The following is a description of a gene set: studied in species Homo sapiens Reactome Pathway: Metabolism of proteins Metabolism of proteins, as annotated here, covers the full life cycle of a protein from its synthesis to its posttranslational modification and degradation, at various levels of specificity. Protein synthesis is accomplished through the process of Translation of an mRNA sequence into a polypeptide chain. Protein folding is achieved through the function of molecular chaperones which recognize and associate with proteins in their non-native state and facilitate their folding by stabilizing the conformation of productive folding intermediates. Following translation, many newly formed proteins undergo Post-translational protein modification, essentially irreversible covalent modifications critical for their mature locations and functions, including gamma carboxylation, synthesis of GPI-anchored proteins, asparagine N-linked glycosylation, O-glycosylation, SUMOylation, ubiquitination, deubiquitination, RAB geranylgeranylation, methylation, carboxyterminal post-translational modifications, neddylation, and phosphorylation. Peptide hormones are synthesized as parts of larger precursor proteins whose cleavage in the secretory system (endoplasmic reticulum, Golgi apparatus, secretory granules) is annotated in Peptide hormone metabolism. After secretion, peptide hormones are modified and degraded by extracellular proteases (Chertow, 1981 ). Protein repair enables the reversal of damage to some amino acid side chains caused by reactive oxygen species. Pulmonary surfactants are lipids and proteins that are secreted by the alveolar cells of the lung that decrease surface tension at the air/liquid interface within the alveoli to maintain the stability of pulmonary tissue. Nuclear regulation, transport, metabolism, reutilization, and degradation of surfactant are described in the Surfactant metabolism pathway. Amyloid fiber formation, the accumulation of mostly extracellular deposits of fibrillar proteins, is associated with tissue damage observed in numerous diseases including late phase heart failure (cardiomyopathy) and neurodegenerative diseases such as Alzheimer's, Parkinson's, and Huntington's., and this is the list of marker genes: MUC13, APCS, COPS8, SPTBN2, SEC61G (SEC61 translocon subunit gamma), FBXO17, MRPL39, GLB1, ALAS1, UBB, TTLL10, FURIN, AGTPBP1, FBXO2, USP17L4, MARS2, RAB8A, CD55, TRAPPC1, DPP4, RPS11, ARF5, CLPP (caseinolytic mitochondrial matrix peptidase proteolytic subunit), TPR, LY6K, SLC25A6, STC2, RAB14, RAB40A, MVD, RPS16, 5S rRNA, ALG13, MRPL38, PSMA7, LMAN1L, RPL13, RBBP5, MRPS33, NAPG, FOLR1, GADD45GIP1, STARD7, PFDN6, ALG11, KBTBD8, RPL36AL, CKAP4, SBSPON, LAMB1, HDAC2, AMELX, KEAP1, PSMA5, SEC24A, SSPOP, EIF2B5, UBE2L3, RAB3A, BTBD1, WAC, SSR1, MUC4, ARFGAP1, NDUFV3, HSPD1, F2, GNG10, UBE2C, PSMD4, NFU1, TMED2, TOP2A, XRN2, DCAF16, FBXL14 (NCBI Gene Id 144699), RGS9, ST6GALNAC3, LY6G6C, PARK7, CST3, KBTBD6, PSMD2, ARSG, B4GALT3, PNPLA2, TARS2, MT-ATP8, ASB8, MRPL41, PIGO, PSME3, USP17L13, AMBN, SMAD1, SMDT1, UBC, USP10, DDX17, CHST4, MTIF2, RAB38, IGFBP5, SRP68, AAAS, ASB17, MGAT4B, TIMM17A, MT-TE, VAMP2, TFAM, STAM, USP17L19, COMMD8, VNN1, MYRIP, LYPD4, TSPAN33, RPS23, SQSTM1, KLHL21 (kelch like family member 21), GATA6, STT3A, UBA3, SOCS6, PARS2, TCP1, PSMF1, HIPK2 (homeodomain interacting protein kinase 2), MT-TV, FSTL3, EIF2B4, ADAMTS3, RGS7, SP3, FBXO22, CLPX, STAM2, MRPL27, CMA1 (chymase 1), EIF3B, USP7, SARS2, ATP5F1B, RPS27A, USP15, SLC34A1, MT-ND3, BMP15, PEX14, TF (NCBI Gene Id 7018), UBE2Z (NCBI Gene Id 65264), TDG, GCG, ST8SIA4, RPS6, MT-TI, FBXO11, CALB1, IDE, CNTN3, GZMH, PPA1, ETFBKMT, PSMD1, RNF181, CTSA, VARS1, RPL13A, GALNT14, UQCRC2, TUBA8, CCT6A, PROS1, H2AC14, UBE2M, FBXO44, NDUFA2, PSMD6, RNF135, MARS1, RBX1, NUP107, LARS1, DYNLL1, COG4, DYNC1LI1, RNF40, TGFB1, DLAT, DCAF13, MRPL28, CES1, AURKB, ADAMTS20, IL6, KLHL2, CALM1, CUL1, KLHL41, ADAMTS16, CCT4, KLHL42, RPLP0, GH1, RRAGA, TRIM4, RPS28, WRN, EARS2, NR5A2, SUDS3, PMM2, NUP133, GGCX, SAA1, AMFR, SENP8, MRPL3, LARGE2, STS, MDC1 (NCBI Gene Id 9656), COPS7B, RPL9, JOSD1, MT-TL2 (mitochondrially encoded tRNA-Leu (CUN) 2), GNAQ, CPM, RNF144A, RAB3D, TUBB2A, SSR3, TMED7, SPTAN1, KGD4, RAET1L (retinoic acid early transcript 1L), ASB2, HCFC1, ASGR1, LTN1, RPS27 (NCBI Gene Id 6232), GALNT2, EXOC5, SEC24C, NFRKB, CUL2, STAMBP, COG8, DCUN1D2, THBS1, SLC25A5, PGAP1, RPS25, FFAR4, TGFBR2, WDR20, TFAP2B, KLK2, MRPS21, CD109, EEF1D, TUBB1, DCAF8, UMOD, APH1B, IZUMO1R, PAPPA, TBCA, ST3GAL6, TOMM70, NARS2, DNAJC24, NCSTN, TARS1, ADAMTS10, SUZ12, PSMD3, OTULIN, F5, MTA1, RNF146, PIGC, TUBA3C, PSMA2, SLC35A4, FBXL8, AGBL1 (NCBI Gene Id 728206), CARS1, AFG3L2, CCNA1, TTLL8, RPL27A, CSNK2A1, MRPS35, RAB39B, MRPL33, SRP19, PRKN, PAPPA2, ZNF598, ACHE, MT-TK, MTIF3, TPGS1, AR, MRRF, GALNTL6, H2AC21, CALCA, NDUFA13, RABGGTB, GOSR2, NUP188, 7SL RNA (ENSG00000222639), PCSK9, STT3B, COG5, ADAMTSL4, EXOC2, SPP2 (NCBI Gene Id 6694), EIF4A2, ABCA3, MT-ND1, EID3, FBXL18, CHRDL1, CSNK2A2, VASH2, RPL26, PGA4, ARRB1, MRPS9, WFS1, CSF2RA, PPARGC1A, ST8SIA5, CUL5, ADAMTS13, METTL22, GNE, ARSA, STX5, COX5A, OPCML, AFP, LONP2, PPA2, ACAT1, SEMG1, PIGN (NCBI Gene Id 23556), PRKACA, RPS9, CYLD, ARSF, TBCB, THSD1, APOA2, NR3C1, RAB22A, UBA52, MTRF1, TNKS2, SEC61B, SP100, GNG2, RAD18, COPS6, ASPH, CUL4A, MSRB1, FFAR1, KCTD6, EIF2B3, RNF7, RAB32, SCMH1, MRPS30, DHDDS, RCE1, EIF2B1, MRPL34, CAMKMT, RPLP2, TRIM28 (NCBI Gene Id 96054), PIGV, ALG12, ANK1, MT-TQ, MUC3B, PSMD9, TECTB, UBE2T, VGF, NLRP3, PSMD5, PPP6R1, NCOA1, CCDC8, RPL39L, ALG8, GPLD1, LRRC41, TBCC, MELTF, NSMCE1, THSD7A, GIP, H2AX, RPN1, ACE2, SNCAIP, PSMA1, RPS4Y2, ACTR5, CTSC (cathepsin C), NUP210, PSMG3, DHPS, POFUT2, FUT3, DPH7, SRP72, B3GNT3, ANKRD28, ALPI, LEP, GGA1, USP13, ASB6, DPM3, CHST10, NUP98, BMI1, FCSK, PLG, UAP1, RPS20, MTRES1, TRIAP1, MTRF1L, RAB9B, KLHL11, MAVS, PLA2G7, STX1A, PMM1, PSMD11, QSOX1, RPL41, FBXO27, RAB27B, ACE, OS9, UBE2D1, ABRAXAS2, ST6GALNAC4, GCNT7, RAB40C, RPS21, SPON2, OST4, GPS1, TADA3, PMPCA, GATA4, NUP58, TSPAN5, NOP56 (NOP56 ribonucleoprotein, NCBI Gene Id 10528), MT-CO2, B4GALT4, TOPORS, FAU, UBE2W, RPS3, RPS10, AXIN2 (NCBI Gene Id 8313), H2BC3, COMMD10, CHM, TGFBI, ATP6AP2, FSTL1, SFTPA2, DPM1, NDUFB6, UBE2A, YARS1, DTL, HDAC3, PARP1, ODAM, ASXL2 (NCBI Gene Id 55252), NR5A1, GAS6, DHRSX, LARGE1, MANEA, SEC22A, OTUD7B, RPS5, TUBA4A, GFM2, PIAS4, DPH5, RPL10, LRR1, H3C1, NEURL2, MRPL55, H2BC14, TNFAIP3, NOD1, PIAS1, ADAMTS2, DNAJC3, DOHH, NTM, COPZ2, FBXL12, TPST1, FBXW10, RAB41 (NCBI Gene Id 347517), CDK1, GALNT16, NR2C1, SERPINC1, RNF103, WDR48, THSD4, ATP5PD, PCGF2, DOLPP1, NRIP1, MT-TP, PPP6C, GOLM1, SOCS3, SIAH1, ASB11, ATXN7, ZDHHC2, COG1, CTSZ, UCHL3 (NCBI Gene Id 7347), MGAT1, H2AC20, ACTR10, PSMD12, MTFMT, USP17L11, AGBL5, MAT2B, MT-RNR2, ADRA2C, USP37, MT-TS2, MRPL44, TFPT, MRPS15, CCT2, MSRA, SPP1, ASB16, JMJD7, PGR, KARS1, RPS29, PSMB3 (NCBI Gene Id 5691), GNB4, MDM2, GBF1, HNRNPC (heterogeneous nuclear ribonucleoprotein C), DNMT3A, MRPL43, CSF2RB, PSMB7, PSMG1, P4HB, ADAMTS18, USP17L12, PLAUR, ITM2B, PUM2, PSMB5, ARSI, ARSH, IGFBP3, TRAPPC4, PSMC3, RAB42, AURKAIP1, H2BC9, CCT3, GBA1, TECTA, RPL36A, REN, PSENEN, KCTD7, HSP90B1, RAB5A, ARG2, BGLAP, COG2, RANGAP1, RAB10, UBXN7, RPL39, INHBE, CGA, TPGS2, CNIH1, PSMC5, ADAMTS9, P2RY2, CCN1, NAPB, RPS26, BMP4, IGFBP1, MRPS6, GFM1, PTEN, TAF10, PCSK2, H2BC15, USP17L10, MT-TL1, FBXO40, USP44, DYNLL2, MBD5, IARS1, ZNF131, CBX5, AGBL3, COPG1, CFP, CSNK2B, LYPD5 (LY6/PLAUR domain containing 5), TTLL6 (NCBI Gene Id 284076), CHCHD2, APOA1 (apolipoprotein A1), COPG2, MRPS2, SAFB, TMED3, ALPG, ARF3 (NCBI Gene Id 377), DCTN5, CDX2, ALDH2, AGT, SPSB4, SPON1, HSPG2, FN3KRP, GAN, UBE2L6, ACO2, SMAD3, HARS2, TGFA, RTF1, MGAT3, OTUB2, JMJD6, RHOT1, CCNA2, SCG2, ALDH1B1, MUC6, SMC5, TRIM25, HEMK2, INO80B (NCBI Gene Id 83444), USO1, CFTR, EIF3G, CRHR2, UFD1, BAP1 (NCBI Gene Id 8314), RAB27A, ELOC, SRPRB, PAF1, MRPS10, LY6H, ZRANB1, PTP4A2, KLHL9, SPCS2, MRPS14, GANAB (NCBI Gene Id 5312), MEN1, TUBB2B, LARS2, H2BC12L, RPL35A, LGALS1, GMPPA, TRAF2, BRCA1, VHL (von Hippel-Lindau tumor suppressor), H2BC11, GNG13, ECI1, RPL29, TRAPPC10, BET1L, RCCD1, PFDN4, NAT8B, RAB2A (RAB2A, member RAS oncogene family), HRC, SDC2, BIRC2, RPL10A, DLST, GOLGB1, GNAT3, USP16, OTUD5, RNF128, PIGT (phosphatidylinositol glycan anchor biosynthesis class T), FUT8, UBA1, HK1, NUP54, YOD1, TADA2B, USP4, USP14, BRCC3, 18S rRNA, PABPC1, RAB29, USP25, GNGT1, ST8SIA1, LYPD1, GNPNAT1, LMAN2L, POMGNT1, CBX4, USP17L18, SERPIND1, CETN2, CHGB, PSMD10, UBE2R2, TRIP4, B3GNT8 (UDP-GlcNAc:betaGal beta-1,3-N-acetylglucosaminyltransferase 8, NCBI Gene Id 374907), RAB39A, THRA, EIF4E, KIF5C, TUBB8B, SEMA5A, ALG10, EEF1A1P5, USP17L22, OXCT1, MRPL15, B3GNT2, FH, MBOAT4 (NCBI Gene Id 619373), TRAF6, SEH1L, DPH6, TIMM22, TRAF3, KIF5B, RPL21, OTUB1, SEMA5B, SOCS2, HDAC4, ERO1B, NANP, H3C15, PCNA, OMA1, FBXW12, FBXO6, CPA3, COP1, RPL36, LMCD1, USP8, MGAT5, PEX12, KBTBD7, MYC, ADAMTS1, OTUD3 (NCBI Gene Id 254897), SKIC8, RING1, MSLN, STAG2, ADGRF5, LIAS, LYZ, TMEM115, SEC11A, BTRC, ARSL, MCRS1, TAB1, OGT, ASB4, PDK1, PSMB1, CCT6B, DYNC1LI2, GCNT4, CUL7, LYPD3, EIF5A2, ADAMTS4, ST3GAL1, CCT5, ST8SIA6, EIF3C, SLC34A2, TRAPPC2L, PSMB11, SATB1, RBBP7, FBXW8, USP12, MRPS11, FKRP, PLET1, GMDS, RECK, TTLL13, WSB2, MT-TH (NCBI Gene Id 4564), NPM1 (NCBI Gene Id 4869), ARCN1, MAN2A1, PGM3, MRPL50, TSPAN14, OXA1L, USP17L5, SUMO1, FBXO30, MRPL20, RAB15, MRPL54, IGFBP2, RAB23, MAN2A2, MRPL13, FBXL19, B2M, ACOT2, ANPEP, NANS, RPL15, COPZ1 (COPI coat complex subunit zeta 1), TOP2B, ADAMTS15 (ADAM metallopeptidase with thrombospondin type 1 motif 15), GFUS, GPIHBP1, TNKS, PPARA, GFPT2, GALNT13, POFUT3, ATXN3L (NCBI Gene Id 92552), EDEM1, NEDD8, PSMD13, CEACAM5, MIA3, DERL2, NOD2, FBXL20, ASB12, PDIA3, FBN1, SEC13, RPS15A, PFDN2, INHBB, NGLY1 (N-glycanase 1), MRPS18A, RPL4, GNG12, SEC22C, MRPL58, SEC11C, GNG3, FBXW7, GMPPB, UBE2B, WARS2, RNF139, TFG, EIF4EBP1, DOLK, BET1, RPS17, MTRFR, RNF152, AMTN, BCHE, TUBB4B, PEX13, RNF20, GALNT7, SPARCL1, SARS1, MT-ND2, RAB21, ARFGEF2, UHRF2, SAE1, RIGI, RAB8B, PRMT3, FUOM, USP18, CP, USP5, DPM2, FBXO10, RPL7A, LONP1, MUC7 (mucin 7, secreted), EIF3L, GALNT1, ADAM10, NUP205, HARS1, SRP54 (signal recognition particle 54), F7, METTL21A, NPPA, HIF3A, NSMCE4A, H2AB1, PDCL, RAB11B, APOA5, FBXW2, SFTPA1, PIGU, ST3GAL4, RPS24, ESR1, TUBA3D, MAN1A1, PEX10, GOLGA2, RPS19, SEC61A1, SSR2, HERC2, MLEC (malectin), ASB9, MRPL10, MMRN1, SAR1B, ACTR1A, FOXK1, SIN3A, DCUN1D3, PGA5, PSMG4, KDELR1, FBXL15, H2BC1, KIFC3, CSF1, TSPAN15 (tetraspanin 15), PDHB, EXOC1, PIGG, MRPS34, POFUT4, MRPS25, RAD21, GNA14, IGF2, SEC23IP, VARS2, SPG7, POMC, PSMC6, COX5B, PSMB9, COMMD7, NAE1, FBXO21, CISH, UIMC1, CNTN5, THBS2, NDUFS1, SRP14, CCP110, CMAS, SSBP1, MRPL40, ADAMTS12, CTBP1, PIGW, PHC1, CCDC22, PROZ, COG3, ECH1, EXOC4, RNF185 (ring finger protein 185), HTRA2, VNN2, RORA, A4GNT, FARS2, MRPL30, UBE2N, H2BC18, CALR, MUC5B, MRPS27, VDAC3, ST6GALNAC1, TBCE, DDOST, BECN1, PSMC4, KAT2B, DCAF6, MGAT4C, ADORA2A (NCBI Gene Id 135), EEF1AKMT1, CPB2, UBE2S, WSB1, UBA2, MRTFA, IGFBP4, NUP88, ASB18, DCAF17, MRPL12 (NCBI Gene Id 6182), COMMD5, PRND, CGB3, TFAP2A, YME1L1, ST6GAL2, MT-CO3, GCSH, QARS1, ADRA2A, HLTF, IAPP, VBP1, SPTBN5, RCHY1, SORL1, ATP5PF, KLK1, CLTRN, FBXL3, TMEM132A (transmembrane protein 132A), NUDT14, GNB2 (NCBI Gene Id 96628), VCAN, USP26, PAAF1, TRAPPC2, FCGR3B, KLK13, RPS4X, FBXO15, YKT6, LTF, NR1I2, MRPL17, COG6, PIGA, COPS2, RARS2, SUMF2, RAB24, MRPS31, WRAP53, NR1H2, ART4, TPST2, MATN3, ADAMTS5, RAB6A, SATB2, LIPT1, NFKBIA, PSMD7, ATP5F1A, AGBL2, TRAPPC6B, ADAMTSL1, KLHL5, LIPT2, PCSK1, SHISA5, TIMM9, CNIH2, ARSD, CLSPN, RPL32, CDC73, TUBB8, SMC3 (NCBI Gene Id 9126), AGBL4, TMEM129, IGFALS, NR1H3, C3 (complement component 3), CARS2, RAB44 (RAB44, member RAS oncogene family), EEF1E1, POMT1, KNG1, RNF168, PIGZ, NR3C2, HSPA8 (NCBI Gene Id 3312), FAM20A, ME2, MT-TY, DCAF4, ADAMTSL3, PIGF, EIF4H, ALDH18A1, RPL22, ETF1, RAB7B, USP28, AXIN1, OGDH, MUC21, TTL, ARFGAP3, ZNF350, MYSM1, TIMP1, SNX3, EIF2S1, MALSU1, TIMM10, SMAD2, COPS5, NUP35, UBXN1, NADK2, RXRA, EIF3M, ARSK, RAB2B, CD59, ATP5MG, FBXL7, MRPL37, SKP1, MRPL32, RNF2, TRMT112, EMID1, ARSB, STAMBPL1, SPTA1, PSMA4, TNIP1, RAB12, C4A, ELOB, MAN1A2, SEC16A, TRAPPC5, DDA1, SEC24D, NUP62, ARF4, CD52, RAB34, RPS13, ST3GAL5, MRPL1, H2AC6, MUC1, SPSB3, ST6GALNAC6, TOMM20 (NCBI Gene Id 9804), BABAM2, ARL2, GALNT6, RPS15, VWA1, CUL4B, PIGH, GPAA1, CUL9, EIF4A1, PSME4, FEM1C, PSMB6, MAP3K7, ALG2, CTNNB1, NUP43, NCOR2, MRPL11, CSNK1D, COL7A1, POM121C, NTNG1, KDM1B, MGAT5B, TUBB3, RPS7, PRSS23, ALB, KIF5A, SENP1, TRAPPC9, H2BC17, MGAT2, WDTC1, EIF5A, ALG5, B4GALT1, H2BC26, SPCS1, PIGQ, RABGGTA, HSD17B10, NEU1, PALB2, TCF7L2, PELO, VDAC2, UBE2V2, GSPT1, MRPL48, EP300, DCTN6, CCT8, ADRM1, TUBA4B, BIRC5, RIOX2, SPHK1, RAB31, INHA, DMBT1, COMMD2, POMGNT2, MRPS28, STAT3, AURKA, TMEM258, USP21, FOXK2, SMURF2, GALNT9, ANKZF1, FBXW4, LHB, GALNTL5, MAN1B1, UBA6, SMAD7, USP33, ADRB2, MRPL4, ASB14, MRPL21, RAB19, ARSJ, SFTPB, GALNT17, EEF1B2, ACTB, RAB25, KAT2A, NEGR1, HADH, FBXW11, MMRN2, RARA, FKBP9, EIF3A, SEC23A (NCBI Gene Id 353367), MT-TT, B3GNT4, MSRB2, GNB1, GRIA1, SELENOS, SEC16B, NUP85, MMP1, INO80D, CDKN2A, ACAD8, GOSR1, USP20, ABCE1, RPL14, TUBA1B, MRPL57, DPP3, AHSG, RPL10L, USP17L20, MRPS16, ANK3, LEO1, ST6GALNAC2, GLUD1, NEMF, GNA15, TGFBR1, GFPT1, RAB4A, UGGT2, PRKCSH, RXYLT1, 28S rRNA, SEL1L, ERAL1, BDH1, ASB1, FBXW9, RIOX1, KLHL22, INHBC, MFGE8, SRD5A3, DDB1, RAD23A, FBXO31, IGFBP6, DMP1, USP2, MT-TG, H2BC4, ADAMTS7, NFE2L2, IDH3A, EIF4G1, SPTBN4, LYPD6B, TNIP3, GARS1, RPS4Y1, FPGT, ZC3H15, EIF5B, SUMF1, ST8SIA2, RAB11A, RAB26, UCHL1, GALNT18, OSTC, ALG3, PIAS2, DDX5, NEU4, SMC1A, COX4I1, PCMT1, UCHL5, DARS1, MXRA8, NRN1L, ST8SIA3, ST3GAL3, FBXW5 (F-box and WD repeat domain containing 5), EEF2, B3GNT9, RAB33A, RAB3C, COPB2, ADAMTS14 (ADAM metallopeptidase with thrombospondin type 1 motif 14), GCNT1, ARRB2, LMAN1, CDCA8, C1GALT1C1, PHC2, DYNC1I1, UBE2H, DCUN1D1, LRRC49, MIA2, H2AC25, GALNT5, GNG5, TTLL11, FARSB, SERPINA1, RUVBL1, KTN1, RPL7 (NCBI Gene Id 6129), TTLL2, PDIA6 (NCBI Gene Id 10130), PIGP (NCBI Gene Id 53821), TSFM, POLB, UBD, CNIH3, NUP50, MRPL36, RPL22L1 (NCBI Gene Id 553116), SEC22B, MRPS5, USP47, MUC17, NSMCE3, OTUD7A, COPE, UCN, H3-3A, MT-RNR1, CRPPA, USP42, RPL5, SPRN, EVA1A, H2BC12, MT-CYB, NEU2, RAB18, OTOA, MRPS23, MT-TW, APOA4, IKBKE, MMP2, RNF5 (ring finger protein 5), US11, TBC1D20, USP9X, RPS8, ARFGAP2, RNF123, RPL31, TAF9B, ASB15, LY6G6D, PROC, NUP93, RPL18A, GORASP1, RAB17, MUC16, RAB30, EIF3D, EPRS1, ACTR8, EIF2S3, CDC34, RPL3, SPTB, CHML, CHCHD1, RPS3A, RPL34, RPS18, USP17L17, UBE2D3, ZBTB16, NTNG2, CTR9, FBXO32, VDR, BLM, NDUFS3, PENK, ULBP2, RPS12, EIF3H, RAB43, USP17L8, JOSD2, FEM1A, B4GALT6, PEX2, ENGASE, ATP5F1C (ATP synthase F1 subunit gamma), SENP5, PAX6, INCENP, DARS2, RPA1, NUB1, RAB5B, FGF23, MT-ND6, OPA1, FECH, IKBKG, CCT7, 5.8S rRNA, RAB7A, MRPL52, SPTBN1, KLHL13, TXN, HLA-A, RAB1A, GALNT4, FOLR2, USP19, NOTUM, TUBB6, MSRB3, THRB, DCUN1D5, BARD1, IFIH1, DNMT1, DRG2, UBE2J2 (NCBI Gene Id 55482), SFTA3, MT-ND5, PREB, RPL18, TTLL5, UBE2E3, APH1A, ST3GAL2, KLHL3, GALNT11, H2AC1, TCF25, MRPL46, HIF1A, B3GNT7, CDC20, ING2, ALG6, ACADSB, UBE2K, USP22, HIC1, SSR4, EEF1G, COMMD3, GPR119, ENPEP, RHOA (ras homolog family member A), WARS1, GNG7, SVBP (NCBI Gene Id 374969), SRPRA, FBXL4, MAN1C1, NAPA, B4GALT5, GGA2, CPE, NEU3, CCNE2, RAB3B, RPS14, MRPL51, PSMB4, MT-ND4L, BST1, TTLL9, MDGA2, HSPA9, UBE2D2, GNGT2, SUCLG2, MICU2, MT-TD, GP2, MUL1, CREBBP, MUC5AC, MT-TS1 (mitochondrially encoded tRNA-Ser (UCN) 1), SMAD4, C1GALT1 (core 1 synthase, glycoprotein-N-acetylgalactosamine 3-beta-galactosyltransferase 1), GRP, LAMB2, FUCA2, RAB6B, RAB5C, USP11, LYPD2, EPAS1, MT-TF, UBE2I (NCBI Gene Id 7329), RPL28 (ribosomal protein L28), RIPK1, NUCB1, ADAMTSL2, APP, VASH1, PFDN5, DAD1, PEX5, CDC25A, GATA3, USP49, TUSC3, PSME1, DCAF10, RPL8, MRPS12, RAB40B, PSMB10, ATXN3 (ataxin 3), PSMC1, PSMA6, NAPSA, YY1, BACE1, RANBP2, STX17, SOCS5, H2AC11, DCTN4, RAE1, ADAMTS19, MRPL24, TUBA1C, SNCA, B4GAT1, CDH2, TWNK, VCPIP1, WDR5, FBXO9, KLK3, ERCC8, USP17L2, TSHB, TOP1, CUL3, RAB37, MT-ND4 (NCBI Gene Id 4538, mitochondrially encoded NADH:ubiquinone oxidoreductase core subunit 4), TTLL7, FGA, NDUFAB1, FOXL2, GNG11, SLC30A8, RAD23B, RPLP1, MT-TN, BABAM1, SIAH2, PGA3, TTR, MRPS22, HDAC1, RPL12, MEPE, UBE2E1, F9, TRIM27, RPL6, LY6D, MPDU1, ENAM, MUC19, CHST8, PSMB8, SEM1, MRPL53, EIF3I, CBX2, MT-TR, USP17L1, TULP4, FKTN, IDH2, NDC1, DERL1, NR4A2, MRPL47, AIMP2, DPH3 (NCBI Gene Id 285381), ATP5PO, MOGS, PSMD8, RPL23, INO80E, MITF, SRP9, ASXL1, TTLL12, NSMCE2, GCNT3, TRAPPC3, GALNT8, PRSS21, GNB3, RPSA, XPC, KDELR3, EEF1AKMT2, DYNC1H1, GNA11, COPA, DPAGT1, UBE2F, EIF2S2, APC, RPL30, ETFB, RPL23A, MRPL18, RARS1, RAET1G, RTN4RL2, DPH1, APOB, MRPS7, ANO8, CBX8 (chromobox 8), MT-TA, ASGR2, GSN, TRAM1, B4GALNT2, ADA2, NARS1, SKIC2, PSMG2, GNG8, PPARG, ADAMTS17, USP34, RPL3L, DLD, TFAP2C, PIGS, POMK, INS (NCBI Gene Id 3630), AMER1, USP17L15, TUFM, PCCB, SLC17A5, EXOC3, SEC24B, FBXO4, EIF3E, RAB1B, NUP153, MT-ATP6, MRPL35, MARCHF6, CHD3, CAPZB, HGS (NCBI Gene Id 9146), POM121, MUC2, SLC30A5, CPB1, F8, RFT1, UBE2G2, IGF1 (NCBI Gene Id 3479), PFDN1, EDEM2, FARSA, ASCC3 (activating signal cointegrator 1 complex subunit 3), SPSB2, VCPKMT, MRPL14, NAGK, EEF1A2, X, SPACA4, FBXL5, MUC3A (mucin 3A, cell surface associated), RPL35, RPN2, RWDD3, FBXL16, PRELID1, NOP58, FGG, NPLOC4, AARS2, H2BC5, NUP37, SUMO2, ISL1, FEM1B, B4GALT2, DCAF7, CAPZA1, AREG, NR1H4, ART3 (NCBI Gene Id 419), MRPL49, TEX101, MIEF1, ST6GAL1, STAG1, CCNF, PIGK, RPS2, GALNT10, H2AZ1, FOXO4, MRPL42, ADAMTS6, MUC15, LY6E, INHBA, RPL17, DCAF5, GALNT3, FBXL13, STAR, GGA3, MDGA1, PSMB2, COMMD1, CNTN4, PIGL, TNIP2, NUP42, CEACAM7 (CEA cell adhesion molecule 7), INO80C (INO80 complex subunit C), ABRAXAS1, DCAF11, PIGY, NFKB2, ICMT, EIF5, RELA, DRG1, B3GNT5, KLHL25, PSME2, KIN, BIRC3, ST6GALNAC5, ALG10B, COPS7A, TUBB4A, MRPL45, TTLL3, ZBED1, USP17L21, CDKN1A, SLC35A1, MDH2, PIGB, SEC31A, F10, SUMO3, NRN1, AP3M1, VDAC1, PIGM (NCBI Gene Id 93183), ASB7, UQCRQ, SLC35C1, RCN1, ADAMTS8 (ADAM metallopeptidase with thrombospondin type 1 motif 8), CCNE1, TNC, LMAN2, DAG1, DCTN2, KLHL20, LTBP1, MYO5A, CASP8AP2, PRL, MRPS24, SEC31B, MT-TC, DPH2, AARS1, ANK2, MRPS17, ADORA2B, OGFOD1, DNMT3B, PSMC2, B3GNT6, RAD52 (NCBI Gene Id 5893), APEH, MRPS18B, H2AC18, TRAPPC6A, MRPL9, RAB4B, MUCL1, IL33, SFTPD, MPI, SFTPC, EXOC7, SHPRH (NCBI Gene Id 282561), RPL27, EEF1A1, RIPK2, NSF, COG7, BPIFB2, PML, TMED9, COPS3, B3GALNT2, SPCS3, EIF3F, RPL11, POMP, DDB2, TTF1, H2BC21, USP17L3, CTSD, MBD6, TBCD, XRCC4, PTRH2 (NCBI Gene Id 51651), COMMD9, KDM8, ASB3, AIMP1, MT-TM, RAB33B, MAGT1, RPL37, SYVN1, CTSG, COMMD4, DCUN1D4, USP30, COPB1, RAB36, TTLL1, MME, OXSM, MDM4, B3GLCT, TGOLN2, GALNT12, RWDD1, KLF4, SCG3, DYNC1I2, RGS11, DAP3, TP53BP1 (tumor protein p53 binding protein 1), APLP2, MUC20 (mucin 20, cell surface associated), RPL38, H2AC12, MUC12, GNG4, CAPZA3, FN3K, MRPL19, GSPT2, PSMA8, NICN1, SEC61A2, EXOC8, MRPS18C, EIF3K, EIF1AX, AMDHD2, FBXL21P, PHC3, FBXL22, APOE, TMED10, PSMA3, CTSH, MRPL16, PTCD3, MCFD2, ASB10, MT-CO1, PIAS3, ASB13, H4C1, THSD7B, APOL1, DCTN3, POMT2, SMC6, H2AC7, JMJD4, 7SL RNA (ENSG00000222619), PPP6R3, SHMT2, SPSB1, GHRL, MBD1, GAPDHS, KBTBD13, VCP (NCBI Gene Id 94731), SCFD1, NUS1, HBS1L, U2AF2, FDX1, MRPL22, FBXO41, EIF3J, TTLL4, FBXO7, GALNT15, QTGAL, NPL (N-acetylneuraminate pyruvate lyase), DCTN1, RPL19, RAB20, NCOA2 (nuclear receptor coactivator 2), FAM20C, MRPL23, PSCA, XPNPEP2, NDUFV1, CCDC59 (NCBI Gene Id 29080), CAPZA2, OBSL1, ADAMTSL5, SKP2, UBE2Q2, RPL37A, TUBAL3, EXOC6, MBTPS1, HMGCS2, TRIM13, CANX, CALU, COPS4, NUP160, IARS2, LAMC1, LMO7, EIF4B, MGAT4A, RGS6, LDHD, ALG14, GNB5 (NCBI Gene Id 82962), USP48, ITIH2, KDELR2, EIF2B2, RENBP, CS, CAND1, MRPS26, DAXX, ASCC2, NAT8, KIF13A, UGGT1, INO80, USP17L24 (NCBI Gene Id 728369), FN1, PRKDC, EDEM3, SERPINA10, LSAMP, FKBP8, USP3, TP53, TRRAP, BCL10, GPC3, FSHB, TUBA1A, SENP2, MRPL2, EIF2AK2, USP24, RAB35, RPS27L, BTBD6, ALG9, PSMD14, ARF1, RAB13, EEF2KMT, NUP155, RAB9A, KLHDC10, ALPL, RTN4RL1, IGFBP7, PRSS41, ALG1, NUP214, ANKRD9, FUCA1, ACTL6A, DBT, ASB5, THY1, L3MBTL2, HLA-B, H2AC4, TUBA3E, PDHA1, H2BC13, LYPD8, UBE2G1, HDAC7, YARS2, PIGX, HNRNPK, COMMD6, RPL24, RPL26L1